The following is a description of a gene set: from publication Kress E, Hedges JF, Jutila MA (PMID 16423401) Human Gene Set: GSE3720_UNSTIM_VS_PMA_STIM_VD1_GAMMADELTA_TCELL_DN studied in species Homo sapiens Genes down-regulated in Vd1 gamma delta T cells: untreated versus phorbol myristate acetate and ionomycin. The two major human gd T cell subsets, Vd1 and Vd2, display differences in tissue tropism and agonist responses, but we have little insight into global differences that may exist at the gene expression level. This is due to the small numbers of these cells that can be obtained from healthy donors, which limit comprehensive, comparative gene expression analyses. We established a culture method that expands Vd1 and Vd2 cells from the same PBL preparation to levels sufficient for sorting and microarray analysis. Although the subsets were expanded identically (anti-TCR mAb, plus IL-15), 392 and genes were identified, which were differentially expressed in the two subsets, from two donors, respectively. Approximately genes changed in both subsets following PMA/ionomycin treatment; about 50% of these genes were subset-specific. Both subsets responded to a crude LPS preparation, but only 6% of the responsive genes were the same. The differentially expressed genes were consistent with Vd2 cells being more inflammatory and Vd1 cells having more of a regulatory phenotype. Both subsets expressed transcripts encoding an array of innate and NK cell receptors, supporting the relationship of gd T cells to the innate immune system. Our results show that circulating Vd1 and Vd2 subsets in humans have considerable, inherent differences in gene expression following treatment with non-TCR agonists, supporting unique functional roles for these cells in vivo., and this is the list of marker genes: MCPH1, KLHDC8B, IL18RAP, MPO, KCNA1, ANGPT2, DGKK, KCNK9, MCOLN3, GNAI1, CLPS, OFCC1, BDNF, SAXO1, ARHGEF12, RIMS3, BLOC1S6, DPY19L1, IQCD, GTF2A1, LRRTM4, GALR2, UPK1A, TCF23, HOXC4, CXCL1, FKBP9, PCDH17 (protocadherin 17), TEKT4, RBL1, GAS6, LMAN2L, MUC1, CC2D2A, ZSCAN5B, FHDC1, RALGAPA2, NEDD1, ADAMTS19, GALNS, MIR411, DIPK1C (divergent protein kinase domain 1C), LAMC1, PDPN, MEIG1, CYYR1, ZEB2, SRGAP3, TASP1, ANKMY2, HTR2C, PLSCR2, WEE1, OGFOD1, AQP1, MIR16-1, RTBDN (NCBI Gene Id 83546), HAVCR2, LRTM1, KCNA5, MIR542, TIE1, ANTXR2, RPS6KA3, DYNLRB2, MYO16, MIR376B, EPS15, MIR300, DCTN4, ERMAP, TMEM87B, PRSS2, NBL1 (NCBI Gene Id 4681), KRTAP19-7, KRT2, MIR31, PHKA1, CDH10, VWC2L, NCKAP1L, TDRD9, PPP1R3C (NCBI Gene Id 5507), DNAJB13, PNLIP, MAGED1, PRKCH, PABPC4 (NCBI Gene Id 8761), GJA10, SYT12, THBS4, PATL1, TUG1, DDIT4L (DNA damage inducible transcript 4 like), PRKDC, MRAP, ATRNL1, TBKBP1, CBR3, MIR9-1, THY1, OOSP2, SCG3, ZZEF1, CASKIN1, AKIRIN2, STAU2, TBXT, ANKS3, MIR34A, CCT8L1P, LBR, AP1S1, KCNJ8, KLK4, SOX4, BTG4, SOWAHC, SMOC1, AS3MT, ACOXL, ZNF318, MRGPRD, CRISPLD2, E2F6, PGF, MIR451A, RUNX1, CLDN25, CYP2E1, SHISA2, TBX4, EHBP1, GREM2, NEBL